The following is a description of a gene set: The series of molecular signals initiated by the binding of the cell surface receptor CD40 to one of its physiological ligands, and ending with the regulation of a downstream cellular process, e.g. transcription. studied in species Mus musculus Mouse Gene Set: GOBP_CD40_SIGNALING_PATHWAY, and this is the list of marker genes: Traf2, Sharpin (SHANK-associated RH domain interacting protein), Itgb1, Cd40, Traf3ip2, Slamf1, Rnf31, Cd40lg, Trem2, Tnfsf18, Tnip2, Fanca, Tnfaip3, Traf6, Fancd2, Itga5, Traf5